The following is a description of a gene set: species: Mus musculus Mouse Gene Set: CUI_NEUTROPHIL_IL18_RESPONSE_UP from publication Cui A, Huang T, Li S, Ma A, Pérez JL, Sander C, Keskin DB, Wu CJ, Fraenkel E, Hacohen N (PMID 38057668) Cytokines mediate cell-cell communication in the immune system and represent important therapeutic targets. A myriad of studies have highlighted their central role in immune function, yet we lack a global view of the cellular responses of each immune cell type to each cytokine. To address this gap, the authors created the Immune Dictionary, a compendium of single-cell transcriptomic profiles of more than 17 immune cell types in response to each of 86 cytokines (>1,400 cytokine-cell type combinations) in mouse lymph nodes in vivo. A cytokine-centric view of the dictionary revealed that most cytokines induce highly cell-type-specific responses. For example, the inflammatory cytokine interleukin-1β induces distinct gene programmes in almost every cell type. A cell-type-centric view of the dictionary identified more than 66 cytokine-driven cellular polarization states across immune cell types, including previously uncharacterized states such as an interleukin-18-induced polyfunctional natural killer cell state. Genes positively differentially expressed in cell type: Neutrophil upon treatment with cytokine: IL-18 in mouse lymph nodes in vivo., and this is the list of marker genes: Bcl2a1d, Casp4, Igtp, Plac8, Nampt, Sod2, Fcgr2b, B2m, Ifi47, Psmb9, Isg15, Gbp2, Psme2, Upp1, Il10rb, N4bp1, Ptafr (NCBI Gene Id 636551), Tnfaip2, Ifitm3, Snx20, Socs1, Bcl2a1a, Ptpn1, Jak2, Stat1, Rnf213, Ltb, Ccl3, Gbp7, Rsad2, Trafd1, Cd274, Tarm1, Parp14, Il1rn, Bcl2a1b, Ctss, Ier3, Gbp5, Lcn2, Rtp4, Cxcl10, Herc6, Vasp, Irgm1, Ifi204, Ehd1, Sh3bp5, Tap1, Pnp, Snx10, Fcgr4 (NCBI Gene Id 320130), Acod1, Mapkapk2, Fth1, Srgn, Cish